The following is a description of a gene set: Human Gene Set: GOBP_TENDON_DEVELOPMENT species: Homo sapiens The process whose specific outcome is the progression of a tendon over time, from its formation to the mature structure. A tendon is a fibrous, strong, connective tissue that connects muscle to bone or integument and is capable of withstanding tension. Tendons and muscles work together to exert a pulling force., and this is the list of marker genes: COMP, NR5A2, BMP4, COL11A1, COL5A1, SCX, GDF7